The following is a description of a gene set: species: Mus musculus Any process that initiates the activity of the inactive enzyme protein kinase C. Mouse Gene Set: GOBP_ACTIVATION_OF_PROTEIN_KINASE_C_ACTIVITY, and this is the list of marker genes: Lep, Sez6l, Abl1, Sez6, Sez6l2, Chrna7